Given this list of marker genes H2-M3, C3 (NCBI Gene Id 12266), Hspd1, Tap2, Rasgrp1, Tgfb1, Cxcl1, Pagr1a, Fcgr1, Scimp, Slamf1, Rsad2, Btk (NCBI Gene Id 215271), Sash3, Lamp1, Fcer1g, H2-T24, H2-Q7, Klhl22, Il18r1, H60b, H2-Ea, Rasgrp4, Hspa8, Pomc, H2-Q6, Azgp1, H2-Q2, Fcer2a, Zbtb1, H2-M2, Cd226, H2-Q10, 6030468B19Rik, Fbxo38, Tfrc, Traf2, Klrd1, Stat5b (signal transducer and activator of transcription 5B), Trem2, Dpp4, Malt1, Exosc3, Slamf6, Stat6, Stat5a, Lag3, Rif1, Traf6, Cd24a, Ccl2 (NCBI Gene Id 20296), Arid5a, Mad2l2, Klrc2, Shld2, Zp3, H2-M10.5, Kmt5b, Ddx21, Prkaa1, H2-T3, Spi1, Tnfsf13, Slc22a13, H2-M1, Raet1e, H2-M10.2, Klre1, Lta, Kmt5c (NCBI Gene Id 232811), Cyrib, Ptafr, Il18, Il1b, Dhx36, Nod2, Stap1, Il23a, Ddx1, Shld3, Cd40, Hmces, Lypd11, Tbx21, Cd1d2, H2-D1, Ifng, Fcer1a, 2410137M14Rik, Tnf, F2rl1, Pnp, Cd28, H2-M9, Shld1, Klrk1, Il12b, Arg1, Foxp3, P2rx7, Kit, Clec7a, Ncr3-ps, Fzd5, Sh2d1a, H2-Q1, Mr1, Gata3, Il21, Stx4a, Trp53bp1, Cd160, Cd55b, Il2, Itgam, Hpx (hemopexin), B2m, H2-T13, Plcg2, H2-M10.6, Klrc1, Gimap3, Itgb2l, Raet1d, H2-M10.1, Msh2, Klrc3 (NCBI Gene Id 58179), Ywhag (tyrosine 3-monooxygenase/tryptophan 5-monooxygenase activation protein, gamma polypeptide, NCBI Gene Id 52802), Cadm1, Ticam1, Map3k7, Xcl1, Pms2, Exosc6, Il1r1, Il12a, Sh2d1b2, H2-T5, Fadd, Tnfsf4, Pvr, Cd55, H2-T15, Stx7, Mlh1, Rigi, H2-M10.3, Ighg1, Vav1, Klrb1c, Cd177, Ighg2b (NCBI Gene Id 16016), Nectin2, Mavs, Dennd1b, H60c, Sh2d1b1, Ap1g1, Prkcz, Il6, H2-T23, Cd1d1, Crtam, H2-T22, H2-K1, Il4, H2-M5, Cd81, Nlrp3, Nsd2, Paxip1, H2-M10.4, Klri2, Tyrobp, Gimap5, Itgb2, Klri1, Lypd10, Clnk, Atad5, H2-Q4, Clcf1, Ptprc, H2-M11, Il18rap, Ulbp1, Fcgr3, here is a description of the gene set: studied in species Mus musculus Any process that activates or increases the frequency, rate, or extent of leukocyte mediated immunity. Mouse Gene Set: GOBP_POSITIVE_REGULATION_OF_LEUKOCYTE_MEDIATED_IMMUNITY